Given this list of marker genes TMEM216, FLI1, CEP290, ARL3, NPHP1, KIAA0586, AHI1, INPP5E, CLCN3, LAMA1, TMEM67, CSPP1, here is a description of the gene set: Abnormal superior cerebellar peduncle morphology Human Gene Set: HP_ABNORMAL_SUPERIOR_CEREBELLAR_PEDUNCLE_MORPHOLOGY An anomaly of the superior cerebellar peduncle. studied in species Homo sapiens